Given this list of marker genes Cd79a, Ptpn6, Cd79b, Igll1, here is a description of the gene set: This event has been computationally inferred from an event that has been demonstrated in another species.<p>The inference is based on the homology mapping from PANTHER. Briefly, reactions for which all involved PhysicalEntities (in input, output and catalyst) have a mapped orthologue/paralogue (for complexes at least 75% of components must have a mapping) are inferred to the other species. part of: Signaling by the B Cell Receptor (BCR) Reactome Pathway: CD22 mediated BCR regulation electronically inferred by orthology from the curated human pathway studied in species Mus musculus